Given this list of marker genes RPL23A, HSD11B2, ECI1, MID1IP1 (MID1 interacting protein 1), PRKG1, FAM110C, APPL2, CDH11, SLC9A2, DNALI1, PIGT (NCBI Gene Id 94004), BMPR2, UNC119, PRRX2, FMOD, VEZF1, BLTP2, ANKRD50 (ankyrin repeat domain containing 50), ETFB, HDGFL3, CA2, SYNJ2BP, GOLM1, ZNF395, SH3BP4, PRKD1, ITGBL1, SKP1P1, NEURL1B, CTSK, TPPP3, RGP1, CCDC74B, ZFHX3, CSNK1A1, DKK3, NQO1, GLI3, SCAMP1, KLHL2, UBE2Q2, here is a description of the gene set: Breast cancer patients with the same stage of disease can have markedly different treatment responses and overall outcome. The strongest predictors for metastases (for example, lymph node status and histological grade) fail to classify accurately breast tumours according to their clinical behaviour. Chemotherapy or hormonal therapy reduces the risk of distant metastases by approximately one-third; however, 70-80% of patients receiving this treatment would have survived without it. None of the signatures of breast cancer gene expression reported to date allow for patient-tailored therapy strategies. Here we used DNA microarray analysis on primary breast tumours of 117 young patients, and applied supervised classification to identify a gene expression signature strongly predictive of a short interval to distant metastases ('poor prognosis' signature) in patients without tumour cells in local lymph nodes at diagnosis (lymph node negative). In addition, we established a signature that identifies tumours of BRCA1 carriers. The poor prognosis signature consists of genes regulating cell cycle, invasion, metastasis and angiogenesis. This gene expression profile will outperform all currently used clinical parameters in predicting disease outcome. Our findings provide a strategy to select patients who would benefit from adjuvant therapy. Human Gene Set: VANTVEER_BREAST_CANCER_BRCA1_DN from publication van 't Veer LJ, Dai H, van de Vijver MJ, He YD, Hart AA, Mao M, Peterse HL, van der Kooy K, Marton MJ, Witteveen AT, Schreiber GJ, Kerkhoven RM, Roberts C, Linsley PS, Bernards R, Friend SH (PMID 11823860) studied in species Homo sapiens Down-regulated genes from the optimal set of 100 markers discriminating ER(-) breast cancer tumors by BRCA1 mutation status.